Given this list of marker genes Dll1, Rps6kb1, Igf2, Actn3, Adrb2, Mtm1, here is a description of the gene set: Mouse Gene Set: GOBP_POSITIVE_REGULATION_OF_SKELETAL_MUSCLE_TISSUE_GROWTH Any process that activates, maintains or increases the rate of skeletal muscle growth. species: Mus musculus